The following is a description of a gene set: The process that gives rise to the paraxial mesoderm. This process pertains to the initial formation of the structure from unspecified parts. Mouse Gene Set: GOBP_PARAXIAL_MESODERM_FORMATION studied in species Mus musculus, and this is the list of marker genes: Wnt3a, Exoc4, Foxc2, Lef1, Wnt11, Htt, Hnf1a, Wnt5a (wingless-type MMTV integration site family, member 5A), Foxc1